The following is a description of a gene set: from publication Boyerinas B, Park SM, Shomron N, Hedegaard MM, Vinther J, Andersen JS, Feig C, Xu J, Burge CB, Peter ME (PMID 18413726) MicroRNAs (miRNA) are small RNA molecules of approximately 20 to 22 nucleotides that reduce expression of proteins through mRNA degradation and/or translational silencing. Each known miRNA has a large number of predicted targets. Members of the let-7/miR-98 family of miRNAs are up-regulated at the end of embryonic development. Let-7 is often down-regulated early during cancer development, suggesting that let-7-regulated oncofetal genes (LOG) may become reexpressed in cancer cells. Using comparative bioinformatics, we have identified 12 conserved LOGs that include HMGA2 and IMP-1/CRD-BP. IMP-1 has growth-promoting activities through stabilization of c-myc mRNA. We experimentally confirmed that IMP-1 is a direct let-7 target that promotes cell growth and motility of tumor cells, and we confirmed by proteomics analysis that IMP-1 and HMGA2 are major miRNA targets. Our data suggest that a substantial part of the growth inhibitory activities of let-7 comes from suppressing the expression of IMP-1. LOGs could be novel therapeutic targets and potential biomarkers for cancer treatment. Human Gene Set: BOYERINAS_ONCOFETAL_TARGETS_OF_LET7A1 studied in species Homo sapiens Embryonic genes targeted by LET7A1 and which are up-regulated in many human cancers., and this is the list of marker genes: FIGN, IGF2BP1, HMGA2, PIGA, NAP1L1, SLC25A24, NME6, COL4A5, LIN28B, CDC34, IGF2BP2, MED6